Given this list of marker genes CARINH, LUCAT1, PRKCA, CHFR, AKIRIN2, PALS2, ECH1, EXOC6, ATXN7L3, NFASC, NDRG3, RPP40, TSNAXIP1, PCBP1-AS1 (PCBP1 antisense RNA 1), NIFKP7, LACTB2, PLEKHA1, CCDC18-AS1, ADCY9, ZNF776, BSG, ALB, CLSTN1, STAU1, ZNF341-AS1, LINC01898, SBK1, BZW2, HMBS, CCDC88A, IKBKB-DT, BLOC1S4, MRPL24, FYCO1, NR1H3, ARAP1, RUFY1, ZNF605, TRABD, CALCOCO1, NPEPPS, EFNA3, HEMGN, FBXO34, WDR82, ZUP1, LINC02928, STAU2, SAXO5, SUMO3, THAP4, PTBP1, ZBTB46, GTF2H4, FBXO38, NPDC1, SCIRT, TXNDC11, ABCA5, CNPY2, DGCR8, TPBGL-AS1, BICDL1, PATZ1, AP2A2, LINC01521, FAXDC2, TMEM160, PRKCSH, AHI1, BUB1B, PLEKHF2, CDC40, ART4, CRADD, ZNF140, WDR87 (NCBI Gene Id 83889), ENAM (NCBI Gene Id 200), LYSMD1, FBXO34-AS1 (FBXO34 antisense RNA 1), AMMECR1, ZNF37BP, NOXO1, LEMD2, XYLT2, CRB1, ZNF649, PROSER2, STARD10, CHD7, MAPT, ANO7 (NCBI Gene Id 50636), MIR1205, CFAP99, RBM6, RNU11, ACACA, HTR1A, LINC02252, ABLIM3, H3-3B, CCDC137, ST7-OT4, CLEC16A, SIPA1L3, CCP110, SFXN1, GIRGL (NCBI Gene Id 100506098), RNU7-55P, ZNF570, DEDD, TRMT12, PI16, PPP2R3B, MIR4729, NPEPPSP1, CCDC88B, SNORA74B, CARD8-AS1, LINC02777, FBXL19, GIT1, FBXL16, RNASEH2C, TPH2, SLF2, SKIL, IL1R1, MYCL, ARMH4, CACYBP, POGLUT1, CAMKMT, LINC01732, BTRC, IZUMO1, SAP30 (Sin3A associated protein 30), ATP13A1, CREBL2, CDKN2AIPNL, MITF, BANP, CRYBG2, PTPRN2, ZBTB14, MIR7-3, GRHL1, MRPL48, HTRA2, TSC22D1, IKBIP, MANEAL, SH2D6, UBAC1, ENSG00000263280, MINDY2, BCORL1, N4BP2L2, DFFA, PRPF31, VTN, PPOX, C17orf58, NSD1, SLC14A1, ENSG00000253986, C6orf89, PREPL, AP3B2, PACS2, PPP4R1L, UBXN4, TFDP1, TMEM11, ENSG00000237346, CPNE2, MIR4531, NRDE2, YEATS2, LHX3, ST7, NUDT13, ASIC4, COX7A2L, KCNK12, NDUFA4, COMMD3, STAT3, TCEA2, TIMM21, SPTBN4, SPINK4, DHX40, TMEM70, TPGS1, STAT5B, TM9SF4, YPEL4, ING3, TXNDC15, MKKS, PNKD, GFM1, PRPSAP1, IRF2BP2, ADAM9, ALG6, SLK, TRIM33, ENSG00000223528, MMACHC, PTDSS2, RNY3P11, PPM1E, NPRL2, MPZ, GAREM2, USE1, RN7SKP245, LYPLA1, LARP1, PCSK6-AS1, FCHSD2, CBFA2T3, SAMD9L, MINDY2-DT, LINC01275, RN7SKP249, KBTBD6, MIR130AHG, SEPHS2, KRTAP2-4 (NCBI Gene Id 85297), GSPT1, UCKL1, TMEM115, BMAL1, FZD3, CPQ, ZNF84, ZNF444, GPR158, PODXL2, TRIB3, TCP11L1, KRBA1, PRSS27, FAM185BP, SH3BP5L, FBXO15, CCDC124, KCNH6, ZNF236-DT, MPND, PHF12, BABAM1, PKN1, B4GALT2, LINC01287, SRCIN1, MIR4309, ENSG00000229797, STRIP1, ZNF688, RNU6-169P, SMIM2-AS1 (NCBI Gene Id 101929212), MICA-AS1, UROS, ERVK3-1, ODAD3, CCZ1B, PCSK6, SNAPC3, RXRA, APAF1, RBL1, PRMT3, GPAT4, SCNM1, KATNBL1P6, SEC61A1, ZSWIM9, ARID4A, LNCATV, UBE2E2-DT, CEP290, ZC3H7A, MRPS22, PGBD5, HSPA9, ACAD8, RNA5SP60, NEUROD4, TLE5, SCAMP4, ABT1P1, ANKS6, AMER3, ENY2, COX7C, SIAH1, CSNK2A1, LARS1 (leucyl-tRNA synthetase 1), TMEM14B, LINC01098, PTK2, TFPT, MYO3B-AS1, DHRSX, GFER, PISD (phosphatidylserine decarboxylase), DESI1, UBE2V1P4, THUMPD2, XKR9, CCDC137P1, PIK3AP1, MEF2C, SEC24C, USP31, DYNC1I2, ZNF484, ADNP, ACTG1, MUS81, BOD1, USP6NL, RN7SKP192, EOGT, ADGRB3-DT, CYB5R3, HTR5A, SNHG5, MEIS2, MIR4766, SEZ6 (seizure related 6 homolog), SYNGR1, NAGLU, SMPD3, TRAJ23, SLX4IP, ARHGAP5-AS1, FAM83A, ZNF615, GNG4, TMEM266, GPKOW, ACP2, RABAC1 (Rab acceptor 1), MIR7-3HG, DOLPP1, CYB5R4, CAMKK2, TOR1A, ZFP37, TAL1, WNK1, MLLT10, FASN, MADCAM1, SYN1, DENND5B-AS1, ACSL3, DNAAF5, ELOC, GALM, NOS3, TMEM11-DT, CUTC, KDM4C, MAPK8IP2, RNU6-218P, CDKL3, MRFAP1, ATG4B, FLYWCH1, FAM117A (family with sequence similarity 117 member A), TMTC3, ZNF417, STAP2, CFL1, MDH1, ZNF236, SCGN, VIPAS39, GPR6, DENND1A, FASTKD1, CABIN1, CRCP, CCDC90B, ZNF225-AS1, FBXL3 (F-box and leucine rich repeat protein 3), ZSCAN31, PADI2, LINC03023, BANCR, RNVU1-15, LASP1, NPPB (natriuretic peptide B), PPP1R12B, CLPX, SLMAP, AP2S1, RIC8A, PGP, EPC1-AS1, FNBP1P1, THADA, RABGAP1L-DT, UBE2O, CCDC146, TCERG1, HM13, CDHR2, LSM10, PRKD3-DT, RNF130, FANCC, ST3GAL2, PA2G4, RAB29, MIR7155, ATG9A, KCNIP2, ERMAP, LINC01929, VARS2, SLC9A3-AS1, CDK5, OSBP2, GNB4, CLP1, ZFYVE1, GRM1, GFUS, SETMAR, CHMP4B, CCDC174, AFG2B, ZNF227 (NCBI Gene Id 7770), CCDC163, KCTD10, UBXN2A, BTBD9, KCNC3, UTP11, STK25, PAFAH2, ADGRB3, IFRD2, RANGAP1, RYBP, EPC1, HDAC8, OPLAH, THYN1, CCDC90B-AS1, WSB1, PTBP3, SUMO2, C11orf21, FBXO38-DT, SRD5A3-AS1, PLAU, IFTAP, ZNF350, CRTC2, MARS1, ZFYVE28, SMARCAL1, PTGES3P2, ZNF225, WDPCP, TMED10, ZMAT1, RANBP10, SFI1, HERC1, PHB1, DDX23 (DEAD-box helicase 23), SMARCA4, DCK, CHCHD2P1, BSCL2, CORO1A, CHGB, COMMD3-BMI1, CLTC, ATG4C, RUNDC3A, GAB2, UBE2Q2, SCRT1, GLRA1, AKR1E2, GPR19, CDCA3, ZNF32, MYO1D, UNK (unk zinc finger), RABGAP1L, MEF2C-AS1, DR1, FAM178B, IMPACT, MYB, GTF2I, HIKESHI, MARCHF2, KBTBD6-DT, MACC1, ZNF585A, LINC02610, TMCC1, HIF1A, TM2D2, PPP2R2C, SLC9A3-OT1, ANKZF1, GYPE, DNHD1, LINC01347, ACVR1B, CXXC1, RAB7A, DNAJB2, SNX12, LINC00824, GNB1, ZBTB38, RN7SKP168, SCG2 (NCBI Gene Id 7857), TMEM181, NSD2, ASAP3, BARHL1, AHSA1, SEL1L, KAT7, ZNF84-DT, PDE4C, TADA2A, DENND5B, RPL23AP77, NNMT, RN7SL75P, OAZ1, SAP30-DT (NCBI Gene Id 124900813), SELENOKP2, PPP1R15A, CMTM3, ACAD10, CADM3-AS1, NOS2P4, UQCRH, PHF13, PHLPP1, UNC13A, NUDCD1, TMCC1-DT, LNCTSI, UBE3C, SEM1, ZNF221, NFIX, CYB561D2 (NCBI Gene Id 11068), CCAR1, C19orf81, SCAF1, TSPAN7, PANK4, ZNF175, THA1P, EHBP1L1, ZNF280D, MIR3124, SHLD1, LHFPL4, RNF6P1 (ring finger protein 6 pseudogene 1), ENSG00000246465, TBX6, COX15, KCNK1, TMEM39A, NRG4, SCG3, KHK, RHOBTB3, CARD8, CASK, GHITM, LINC02178, SNAP25-AS1, GP6, ALG1L13P, LRRC41, ARHGAP5, AUP1, NEK6, XIST, CBX7, FCSK, ZNF821, WWP1, SYT3, PTPRN, BTNL9, AHCYL2, NFE2, RUNDC3A-AS1, ENSG00000223598, NR3C1, DAZAP1, CARMIL2, VCPIP1, GRK3-AS1, MAX, LEPROTL1, SRRM3, RUNX1T1, ZNF569, UBA5, SCAMP5, KCNAB1, MAN2A2, USF2, UBTF, LHFPL5, ADAT3, IKZF2, GP6-AS1, PIPOX, KBTBD7, IKZF4, RIN3, SH3GL1, PPP1R12C, SLC4A2, RNF144A, CELF6, CAPG, NOP53, MYL4, RPS26, APBB1, GRK3 (G protein-coupled receptor kinase 3), AAMP, WASF1, ARRDC3 (arrestin domain containing 3), MIER1, TACO1, C1orf159, SGPL1 (NCBI Gene Id 8879), HMX3, RNA5SP324, NOSIP, PUM3, LINC01088, ZNF331, LIG1, PIGL, TBL1X, TULP2, METTL3, UBE2E2, PRKD3, CDH23, ATF7IP2 (activating transcription factor 7 interacting protein 2), PSMA3-AS1, GNB1-DT, OTUD7A, CPEB4, here is a description of the gene set: species: Homo sapiens from publication Yevshin I, Sharipov R, Kolmykov S, Kondrakhin Y, Kolpakov F (PMID 30445619) Human Gene Set: ZNF197_TARGET_GENES Genes containing one or more binding sites for (ZNF197) in their promoter regions (TSS -1000,+100 bp) as identified by GTRD version 20.06 ChIP-seq harmonization.